Given this list of marker genes PRKCB, CRK, BCAR1, PRKCG, PTK2B, PXN, PRKCA, PTK2, here is a description of the gene set: species: Homo sapiens Human Gene Set: KEGG_MEDICUS_PATHOGEN_HCMV_US27_TO_CXCR4_GNB_G_PLCB_PKC_SIGNALING_PATHWAY Pathway Definition from KEGG: US27 -> Ca2+ -> PKC -> PTK2B -> (PTK2+BCAR1+CRK+PXN) HCMV US27 to CXCR4-GNB/G-PLCB-PKC signaling pathway. Pathway ID: N00414. Pathway type: Pathogen. Pathway class: nt06167 Human cytomegalovirus (HCMV).